The following is a description of a gene set: Epiretinal membrane An epiretinal membrane is a thin sheet of fibrous tissue that can develop on the surface of the macular area of the retina and cause a disturbance in vision. An epiretinal membrane area can develop on the thin macular area of the retin. An epiretinal membrane is also sometimes called a macular pucker, premacular fibrosis, surface wrinkling retinopathy or cellophane maculopathy. studied in species Homo sapiens Human Gene Set: HP_EPIRETINAL_MEMBRANE, and this is the list of marker genes: NDP, APC, ZNF408, LRP5, C1QTNF5, TRNT1, NF2, NLRP3, HLA-A, HGSNAT, CTNNB1, FZD4, TSPAN12